Given this list of marker genes Gtf2h2, Fancc, Brip1, Dpf1, Rad23a (NCBI Gene Id 93802), Arid1a, Nthl1, Pbrm1, Actb, Poll, Smarca4, Smarcb1, Hmgb1, Mnat1, Smarcd2, Gtf2h1, Cul4a, Kat5, Ercc5, Rad52, Bcl7c, Ercc6, Pold3, Smarcc2, Xpc, Arid2, Commd1, Smarce1, Smarcd1, Dpf3, Bcl7b, Kat7, Ercc8, Rad23b, Gtf2h5, Smarcd3, Cetn2, Uvssa, Pole, Bcl7a, Rpa2, Hus1, Ercc4, Sirt1, Usp7, Ercc1, Hmgn1, Gtf2h4, Brd7, Smarcc1, Ercc3, Ddb2, Gtf2h3, Actl6b, Dpf2, Dclre1a, Hus1b, Rpa3, Rpa1, Actl6a, Xab2, Lig4, Xpa, Polr2i, Smarca2, Ercc2, Phf10 (PHD finger protein 10), Brca2, Ogg1, Trp53, Slx4, Pold1, Fan1, Dclre1b (DNA cross-link repair 1B), Polk, here is a description of the gene set: A DNA repair process in which a small region of the strand surrounding the damage is removed from the DNA helix as an oligonucleotide. The small gap left in the DNA helix is filled in by the sequential action of DNA polymerase and DNA ligase. Nucleotide excision repair recognizes a wide range of substrates, including damage caused by UV irradiation (pyrimidine dimers and 6-4 photoproducts) and chemicals (intrastrand cross-links and bulky adducts). studied in species Mus musculus Mouse Gene Set: GOBP_NUCLEOTIDE_EXCISION_REPAIR